Given this list of marker genes Rhcg (Rhesus blood group-associated C glycoprotein), Aqp1, Aqp6, Rhbg, Rhag, here is a description of the gene set: The process in which carbon dioxide (CO2) is transported across a membrane. Mouse Gene Set: GOBP_CARBON_DIOXIDE_TRANSMEMBRANE_TRANSPORT species: Mus musculus